The following is a description of a gene set: Mouse Gene Set: GOCC_NLRP3_INFLAMMASOME_COMPLEX species: Mus musculus An inflammasome complex that consists of three components, NLRP3 (NALP3), PYCARD and caspase-1. It is activated upon exposure to whole pathogens, as well as a number of structurally diverse pathogen- and danger-associated molecular patterns (PAMPs and DAMPs) and environmental irritants. Whole pathogens demonstrated to activate the NLRP3 inflammasome complex include the fungi Candida albicans and Saccharomyces cerevisiae, bacteria that produce pore-forming toxins, including Listeria monocytogenes and Staphylococcus aureus, and viruses such as Sendai virus, adenovirus, and influenza virus., and this is the list of marker genes: Dhx33, Casp1, Nlrp1b, Nlrp1a, Nlrp3, Ddx3x (DEAD box helicase 3, X-linked), Gsdmd, Pycard